The following is a description of a gene set: studied in species Mus musculus Mouse Gene Set: GOBP_NEGATIVE_REGULATION_OF_NUCLEOTIDE_METABOLIC_PROCESS Any process that stops, prevents, or reduces the frequency, rate or extent of the chemical reactions and pathways involving nucleotides., and this is the list of marker genes: Ncor1, Mtch2, Ppara, Fbp1 (fructose bisphosphatase 1), Hdac4, Trp53, Actn3, Ddit4, Pfkfb1, Slc4a1, Ppp2ca, Myog, Entpd1, Sirt6, Pid1, Tspo (NCBI Gene Id 12257), Git1, Fis1, Prkaca, Nupr1, Atp5if1, Aldob, Trim63, Cda, Parp1 (poly (ADP-ribose) polymerase family, member 1), Ppargc1a, Ier3, Tigar, Rd3, Cbfa2t3, Flcn, Sik2, Gpi1, Stat3